The following is a description of a gene set: The chemical reactions and pathways resulting in the formation of pyrimidine nucleoside triphosphate, a compound consisting of a pyrimidine base linked to a ribose or deoxyribose sugar esterified with triphosphate on the sugar. species: Homo sapiens Human Gene Set: GOBP_PYRIMIDINE_NUCLEOSIDE_TRIPHOSPHATE_BIOSYNTHETIC_PROCESS, and this is the list of marker genes: DTYMK, NME5, NME2, TYMS, TBPL1, CTPS2, NME4, NME7, NME1 (NME/NM23 nucleoside diphosphate kinase 1), NME9, NME6, CMPK2, NME2P1, UCK2, UCK1, CTPS1, CAD, UCKL1, NME3